The following is a description of a gene set: Human Gene Set: GOBP_GLUCOSYLCERAMIDE_CATABOLIC_PROCESS species: Homo sapiens The chemical reactions and pathways resulting in the breakdown of glucosylceramides, any compound formed by the replacement of the glycosidic hydroxyl group of a cyclic form of glucose by a ceramide group., and this is the list of marker genes: GBA3, SCARB2, MIR195 (NCBI Gene Id 406971), PRKCD, MIR16-1, GBA2, MIR127, GBA1